Given this list of marker genes RAB35, RCSD1, ARL8B, WASHC2A, RDX, ARF6, EZR, ABHD17B, VPS35, ANKRD13A (ankyrin repeat domain 13A, NCBI Gene Id 88455), NRP1, ROCK2, SORL1, VEGFA, TMEM30A, MGAT3, WASHC2C, MSN, TOLLIP, EGF, MICALL1, PACSIN2, DTX3L, ABHD17C, ABHD17A, NF2, AKAP11, here is a description of the gene set: studied in species Homo sapiens A process in which a protein is transported to, or maintained in, a location within an endosome. Human Gene Set: GOBP_PROTEIN_LOCALIZATION_TO_ENDOSOME